Given this list of marker genes SRC, PPP2CA, GRB2, FGF2, PPP2R1A, FGF17, FGFR3, MKNK1, GAB1, FRS3, MAPK3, UBC, GALNT3, FGF23 (NCBI Gene Id 8074), FGF4, FGF16, CBL, RPS27A, PTPN11 (NCBI Gene Id 84990), FGF18, NRAS, FRS2, FGF1, MAPK1, PIK3R1, UBA52, FGF9, BRAF, HRAS, PPP2CB, FGF5, SHC1, PLCG1, FGF8, SOS1, KRAS, UBB (ubiquitin B), PIK3CA, FGF20, SPRY2, here is a description of the gene set: species: Homo sapiens Signaling by FGFR3 Human Gene Set: REACTOME_SIGNALING_BY_FGFR3